The following is a description of a gene set: Any process involved in mediating the movement of discrete segments of DNA between nonhomologous sites. For elements that are transcribed as the first step of transposition, the process starts with the transcription of the transposable element, its translation and maturation, and ending with integration into DNA. For elements that are cut out, the process starts with the excision of the donor DNA and integrated into another site. species: Homo sapiens Human Gene Set: GOBP_TRANSPOSITION, and this is the list of marker genes: SETDB1, APOBEC3A, TDRD12, SPIN1, PIWIL4, MPHOSPH8, ASZ1, TASOR, MOV10, L1TD1, TUT4, UBR2, TEX19, APOBEC3H, PGBD5, THAP9, TDRD1, APOBEC3G, TUT7, PIWIL2, ZFP92, MORC1, DNMT3L (DNA methyltransferase 3 like), DDX4, FKBP6, C19orf84 (NCBI Gene Id 147646), APOBEC3B, DNMT3A, MORC2, SIRT7, TEX15, ZNF93, TREX1, TDRD9, SPOCD1, APOBEC3F (apolipoprotein B mRNA editing enzyme catalytic subunit 3F), SMYD5 (NCBI Gene Id 10322), PIWIL1 (piwi like RNA-mediated gene silencing 1), BTBD18 (BTB domain containing 18), MOV10L1, ZNF91, TDRD5, MAEL, RESF1, APOBEC3C, SIRT6